Given this list of marker genes Vegfc, Tgfbr1, Fermt2, Bmp4, Ltbp3, Ccne1, Tgfb1, here is a description of the gene set: Mouse Gene Set: GOBP_REGULATION_OF_MESENCHYMAL_STEM_CELL_PROLIFERATION studied in species Mus musculus Any process that modulates the frequency, rate or extent of mesenchymal stem cell proliferation.